The following is a description of a gene set: Human Gene Set: HESSON_TUMOR_SUPPRESSOR_CLUSTER_3P21_3 Deletions of the 3p21.3 region are a frequent and early event in the formation of lung, breast, kidney and other cancers. Intense investigation of allelic losses and the discovery of overlapping homozygous deletions in lung and breast tumour-cell lines have defined a minimal critical 120 kb deletion region containing eight genes and likely to harbor one or more tumour-suppressor genes (TSGs). The candidate genes are HYAL2, FUS1, Ras-associated factor 1 (RASSF1), BLU/ZMYND10, NPR2L, 101F6, PL6 and CACNA2D2. Recent research indicates that several of these genes can suppress the growth of lung and other tumour cells. Furthermore, some genes (RASSF1A and BLU/ZMYND10) are very frequently inactivated by non-classical mechanisms such as promoter hypermethylation resulting in loss of expression. These data indicate that the 120 kb critical deletion region at 3p21.3 may represent a TSG cluster with preferential inactivation of particular genes depending on tumour type. The eight genes within this region and their potential role in cancer will be the focus of this review. from publication Hesson LB, Cooper WN, Latif F (PMID 17533367) studied in species Homo sapiens Genes in the tumor suppressor cluster of the 3p21.3 region., and this is the list of marker genes: ZMYND10, CACNA2D2 (calcium voltage-gated channel auxiliary subunit alpha2delta 2), RASSF1, FUS, NPRL2 (NCBI Gene Id 10641), HYAL2, CYB561D2 (NCBI Gene Id 11068), TMEM115